The following is a description of a gene set: species: Homo sapiens Genes containing one or more binding sites for (GTF3C1) in their promoter regions (TSS -1000,+100 bp) as identified by GTRD version 20.06 ChIP-seq harmonization. Human Gene Set: GTF3C1_TARGET_GENES from publication Yevshin I, Sharipov R, Kolmykov S, Kondrakhin Y, Kolpakov F (PMID 30445619), and this is the list of marker genes: MIR6828, NCAM2, MT-TF, RFX1, PRR13, STX6, MT-TP, SLC66A1LP, MT-RNR1